The following is a description of a gene set: species: Homo sapiens Cardiac conduction Human Gene Set: REACTOME_CARDIAC_CONDUCTION, and this is the list of marker genes: ASPH, ITPR3, KCNA5, NPPA, ATP2B3, CACNG4, SLC8A2, ATP1A4, AKAP9, CES1, KCNK2, SLC8A3, KCNIP2, SCN4A (sodium voltage-gated channel alpha subunit 4), SCN2A, SCN4B, RANGRF, KCNK13, KCNIP1, KCNK17, ATP2A2, KCNK5, KCNJ11, KCNK3, SCN7A, KCNE1, GATA4, SCN11A, STIM1, ATP2B1, RYR2, CORIN, KCNK9, FGF11, CACNB1, KCNJ2, SLC8A1, ABCC9, ATP2B2, CASQ2, FXYD1 (FXYD domain containing ion transport regulator 1), KCNK4, SRI, SCN10A, KCNJ4, KCNE2, SCN8A, FXYD2, CACNA1C, PRKACA, CACNB2, SCN3A, CLIC2, FXYD6, NPPC, SCN9A, KAT2B, FGF12, ATP1B2, KCND3, FGF14, KCNJ12, SCN5A, MME, WWTR1, TBX5, CAMK2D, KCNK12, ATP1A1, HIPK1, KCNE3, NOS1, ATP1B3, KCND1, NPR2, ATP2A1, CAMK2A, SCN2B, KCNK1, ORAI1, NKX2-5 (NCBI Gene Id 1482), ATP2A3, FXYD4, ATP2B4, FXYD7, CAMK2G, KCNK7, KCNE4, FKBP1B, ATP1A3, KCNIP3, KCNK18, SCN1B, SCN3B, SLN, KCNIP4, DMPK, CALM1, ORAI2, ITPR1, KCNK6, FGF13, TRPC1, KCNE5, TRDN, SCN1A, KCNQ1, RYR3, CASQ1, ATP1B1, KCNK16, KCNK10, CACNA2D2, ATP1A2, HIPK2 (NCBI Gene Id 653052, homeodomain interacting protein kinase 2), CAMK2B, FXYD3, CACNG6, CACNG7, CACNG8, NPR1, KCND2, AHCYL1, TNNI3, KCNJ14, PLN, RYR1, KCNH2, KCNK15, ITPR2